The following is a description of a gene set: Genes containing one or more binding sites for (Tbx4) in their promoter regions (TSS -1000,+100 bp) as identified by GTRD version 20.06 ChIP-seq harmonization. species: Mus musculus Mouse Gene Set: TBX4_TARGET_GENES from publication Yevshin I, Sharipov R, Kolmykov S, Kondrakhin Y, Kolpakov F (PMID 30445619), and this is the list of marker genes: Ttc39d, 2600014E21Rik, Poldip3, Scamp3, Usf3 (upstream transcription factor family member 3), Wnt11, Mov10, Rhobtb1, Glul, Npm3, Arid1a, Pcnp, Mir199a-2, Dapk3, Hoxa7, Trip12, Bahcc1, 1700041G16Rik, Rpl27, Proser1, Syne2, Mir615, Nat10, Mir6936, Calm2, Tex14, Hoxa9, Fgfr2, Psmg1, Cul4b, Spata31e2, A730013G03Rik, Psen1, Slx4ip, Meis2, Specc1, Hmgn2, Hcfc1r1, Gm17494, Neurl4, Zcwpw2, Tenm3, 1700096K18Rik, Zfp142, Klf7, P4ha2, Klhdc3, Epn1, Mkks, Dnajc1, Ccpg1, Harbi1, Rasgef1b (RasGEF domain family, member 1B), Scfd1, Gm11772, Fzd2, Mmaa, Rex1bd, Eva1b, Rab5b, Ppip5k2, Amotl2, Adnp, Amdhd2, Rbm25, Lsm7, Lrrc17, Ubl3, Chd2 (chromodomain helicase DNA binding protein 2), Mynn, Gm11511, AU015336 (NCBI Gene Id 106309), Fbxo36, Litaf, Tbx4, Ccng2, Igf2bp3, Arl2, Atg13, Nhlrc3, Tuba1a, Azi2, Pold3, Dnajb5, Dgkz, Sema6a, Gng8 (guanine nucleotide binding protein (G protein), gamma 8), Zc3h6, Zfat, 9430024E24Rik, Lmln, Vps51, Akap13, Fdx2, Gm12111, Pcyt1a, Uck2, Mrpl12, Sulf1, Bmpr1b, Cpsf6, Rsrc1, 2810408A11Rik, Glce, Cfap43, Tm7sf2, Efnb3, Srsf7, Dnm3os, Gabarap, Pierce2 (piercer of microtubule wall 2), Rnu12, Mir5133, Hoxa11os, Grcc10, Prrx1, Dnaaf5, Rdm1, Rsrp1, Mtfr2, Mir8114, Gm13652, Grid2ip, Galnt5, Eapp, Gm15831, Sirt7, Gm4890, Cacnb2, 2900072N19Rik, Sesn1, Col9a1, Cenpu (centromere protein U), Ephb4, Riiad1, Pop7, Tmem132a, Tmem52b, Pde4d, Gpx1, Rsbn1, Gm2453, Abraxas2, Smc5, Mir199a-1, Ccdc97, Bcs1l, Scube3, Nfkb1, Gtf3c6, AA474408, Hoxd8, Vgll4, Sppl2b, Mir760, Wdr24, Polg2 (polymerase (DNA directed), gamma 2, accessory subunit)